Given this list of marker genes B130055M24Rik, Hnrnpa0, C430014B12Rik, Kdm1a, Oxsm, Eif4h, Mir1893, Skp1, Rpgrip1l, Smarce1, Ythdf2, Senp6 (NCBI Gene Id 74825), 9230114K14Rik, Slc10a7, Chmp3, Zfp326, Dnajb4, Ckap5, Mapk8ip3, Mff, Zic4, Hnrnpr, Sdhaf2, Usp3, Rnls, Ino80d, 2610037D02Rik, Tcf12, 6330562C20Rik, Scrt1, 1600020E01Rik, Fto, Macf1, Gm10222, mt-Cytb, Mbd5, Ino80dos, Evi5, Zmynd11, Ahcyl1, Tyw5, Ube2i, Usp7, Ngly1, here is a description of the gene set: Genes containing one or more binding sites for (Ncoa1) in their promoter regions (TSS -1000,+100 bp) as identified by GTRD version 20.06 ChIP-seq harmonization. from publication Yevshin I, Sharipov R, Kolmykov S, Kondrakhin Y, Kolpakov F (PMID 30445619) Mouse Gene Set: NCOA1_TARGET_GENES species: Mus musculus